Given this list of marker genes Igtp, Cfl1, Capg, Tap2, Stat1, Parp9, Ifi47, Il12rb1, Stat3, Gbp2, Psmb10, Manf, Cxcl10 (NCBI Gene Id 15945), Dhx29, Cycs, Bak1, Gbp4, Calm1, Calhm6, Irgm2, Serpina3g, Pfkp (phosphofructokinase, platelet), Serpina3f, here is a description of the gene set: Cytokines mediate cell-cell communication in the immune system and represent important therapeutic targets. A myriad of studies have highlighted their central role in immune function, yet we lack a global view of the cellular responses of each immune cell type to each cytokine. To address this gap, the authors created the Immune Dictionary, a compendium of single-cell transcriptomic profiles of more than 17 immune cell types in response to each of 86 cytokines (>1,400 cytokine-cell type combinations) in mouse lymph nodes in vivo. A cytokine-centric view of the dictionary revealed that most cytokines induce highly cell-type-specific responses. For example, the inflammatory cytokine interleukin-1β induces distinct gene programmes in almost every cell type. A cell-type-centric view of the dictionary identified more than 66 cytokine-driven cellular polarization states across immune cell types, including previously uncharacterized states such as an interleukin-18-induced polyfunctional natural killer cell state. Genes positively differentially expressed in cell type: ILC (innate lymphoid cell) upon treatment with cytokine: IL-15 in mouse lymph nodes in vivo. Mouse Gene Set: CUI_ILC_IL15_RESPONSE_UP species: Mus musculus from publication Cui A, Huang T, Li S, Ma A, Pérez JL, Sander C, Keskin DB, Wu CJ, Fraenkel E, Hacohen N (PMID 38057668)